The following is a description of a gene set: from publication Chen Y, Wang X (PMID 31504780) Genes predicted to be targets of miRBase v22 microRNA mmu_miR_547_3p in miRDB v6.0 with MirTarget v4 prediction scores > 80 (high confidence targets). Mouse Gene Set: MIR_547_3P species: Mus musculus, and this is the list of marker genes: Abce1, Arid1b, Polr3a, Zic1, Zswim6, Slc38a2, Cwf19l2, Col4a2, Slc44a5, Phospho2, Mbtd1, Zmym2, Enpep, Slc6a18, Pafah1b1, Ccdc88a, Mcmbp, Enpp2, St8sia4, Slc2a2, Krtap12-22, Tacr3, Klf4, Zfp764, Efna3, Specc1l, Hnrnpab, Stxbp4, Ano1, Rnf19a, Mdh1, Slc25a26, Pitpnm2, Zfp217, Ccdc120, Pik3r3, Raph1, Klf12, Traip, Rock1, Klhl29, Sh3bgrl2, Esyt2, Anks1, Ryr3, Gucy1a2, Adcy1, Pdgfrb, Trmt6, Nell1, Cts7, Plpp2, Atp11c, Insyn2b, Trpa1, Zfp42, Ptpn13, Tmem150a, Copb1, Gosr1, Armcx2, Rp2, Ube2g1, Nexmif, Muc20, Dr1, Zfp764l1, Strn, Calb2, Dyrk1b, Inpp4a, Lyrm4, Spock1, Magohb, Map4k4, Hycc2, Cdh2, Ctcf, Plxnc1, Ginm1, Map2k4, Paip1, Slc7a14, Lrit2, B3galnt2, Cd164, Slc5a3, AI593442, Arhgef2, Tmem179b, Micu3, Cdc14a, Ttr, Mpp3, Tnrc6c, Stc1, Trub1, Zfp930, Ralgapa1, Adcy2, Emc3, Wdr44, Pde8b, Csgalnact2, Xrn1, Prkaa2, Igf1, Arhgap6, Snx25, Cxcr5, Zfhx3, Arhgap24, Ptgfrn, Tlnrd1, Prtg, Rfx3, Mllt3, Tmem185b, Mitf (NCBI Gene Id 17342), Usp46, Lrrc8c, Bahd1, Col9a1, Dyrk1a